The following is a description of a gene set: Human Gene Set: WP_CELL_CYCLE studied in species Homo sapiens Cell cycle, and this is the list of marker genes: EP300, PKMYT1, BUB1, ORC1, MAD2L2, CDKN2C, MYC, RB1, CDK2, ANAPC2, CCND1, SKP1, E2F4, ZBTB17, CDC45, ORC6, YWHAE, PTTG2, CDKN1C, RBL1, CCNA2, ORC5, GADD45A, CDKN2D, CDC6, SMC1B, CDC25B, CCNA1, PRKDC, RBL2, YWHAG, PLK1, SMC1A, MCM7, RBX1, SMAD4, CDC16, ESPL1, STAG1, TFDP1, E2F3, ANAPC10, YWHAH, CDC14B, CDC25C, CCNB2, PTTG1, E2F2, FZR1, CDKN2A, CCNH, MCM3, CDC7, TP53, STAG2, SMC3, CDK6, CHEK2, TGFB3, ANAPC7, CDC14A, ANAPC5, ATR, TGFB1, DBF4, ANAPC13, YWHAQ, CDKN1A, MCM5, SMAD2, MCM2, HDAC2, ANAPC1, CDC25A, SFN, CDK1, GSK3B, CCNB1 (cyclin B1), SKP2, MCM6, HDAC1, ATM, MAD1L1, CDC27, CDKN1B, TFDP2, CDKN2B, CDC20, CDC23, ORC2, ORC3, ORC4, CCND3, RAD21, CCNB3, CCND2, GADD45B, MDM2, ABL1, CDK4 (NCBI Gene Id 92978), TTK, BUB3, E2F1 (NCBI Gene Id 1869), PCNA, ANAPC4, E2F5, CCNE2, CUL1, WEE1, MCM4, SMAD3, ANAPC11, YWHAB, WEE2, CCNE1, YWHAZ, CDK7, TGFB2, CHEK1, GADD45G